Given this list of marker genes GABRR2, HEPH, SOX10, CFD, NPR1, AGR2, HOXA9, KRT20, KLF5 (NCBI Gene Id 688), HOXA2, NOTCH3, MUC2, MUC6, FABP2, SCT, HOXA7, CDX1, DNMT3B, TSPAN1, CDX4, FABP6, PSEN2, MSI1, KLF4, SI, JAG1, IL2RB, ANPEP, VDR, NOTCH4, ATOH1, PGC, VIL1, NPR3, LYZ, here is a description of the gene set: studied in species Homo sapiens Genes up-regulated in HET1A cells (esophagus epithelium) engineered to stably express CDX2. from publication Liu T, Zhang X, So CK, Wang S, Wang P, Yan L, Myers R, Chen Z, Patterson AP, Yang CS, Chen X (PMID 16990345) Human Gene Set: LIU_CDX2_TARGETS_UP Caudal-related homeobox 2 (Cdx2) has been suggested as an early marker of Barrett's esophagus (BE), which is the premalignant lesion of esophageal adenocarcinoma (EAC). However, the mechanism of ectopic Cdx2 expression in the esophageal epithelial cells and its role in the development of BE remained unclear. RT-PCR, pyrosequencing and methylation-specific PCR were used to determine expression and promoter methylation of Cdx2 in human esophageal epithelial cells (HET1A and SEG1) after treatment with 5-aza-2'-deoxycytidine (DAC), acid, bile acids and their combination. HET1A cells with stable transfection of Cdx2 were characterized for morphology and gene expression profiles with Affymetrix array. We found Cdx2 was expressed in most human EAC cell lines, but not in squamous epithelial cell lines. DAC-induced demethylation and expression of Cdx2 in HET1A and SEG1 cells, and treatment with a DNA methylating agent counteracted the effect of DAC. Treatment of HET1A and SEG1 cells with acid, bile acids or both also resulted in promoter demethylation and expression of Cdx2. HET1A cells with stable transfection of human Cdx2 formed crypt-like structures in vitro. Microarray analysis and quantitative real-time PCR showed that stable transfection of Cdx2 up-regulated differentiation markers of intestinal columnar epithelial cells and goblet cells in HET1A cells. This may be partially due to modulation of Notch signaling pathway, as western blotting confirmed down-regulation of Hes1 and up-regulation of Atoh1 and Muc2. Our data suggest that exposure to acid and/or bile acids may activate Cdx2 expression in human esophageal epithelial cells through promoter demethylation, and ectopic Cdx2 expression in esophageal squamous epithelial cells may contribute to intestinal metaplasia of the esophagus.